The following is a description of a gene set: Mouse Gene Set: WP_DYSREGULATED_MIRNA_TARGETING_IN_INSULINPI3KAKT_SIGNALING studied in species Mus musculus Dysregulated miRNA targeting in insulin/PI3K-AKT signaling, and this is the list of marker genes: Mir155, Ccnd2, Bad, Mapk3, Bcl2l11, Prkx, Col1a1, Fasn, Cdkn1b, Col5a3, Sos1, Raf1, Prkar2a, Col3a1, Eif4e2, Flot2, Pik3r3, Bcl2, Col1a2, Socs1, Acaca, Col4a2, Rheb, Pik3r1, Mtor, Crkl, Exoc7